The following is a description of a gene set: from publication Fridman AL, Tainsky MA (PMID 18711403) Genes down-regulated in senescent cells. studied in species Homo sapiens Bypassing cellular senescence and becoming immortal is a prerequisite step in the tumorigenic transformation of a cell. It has long been known that loss of a key tumor suppressor gene, such as p53, is necessary, but not sufficient, for spontaneous cellular immortalization. Therefore, there must be additional mutations and/or epigenetic alterations required for immortalization to occur. Early work on these processes included somatic cell genetic studies to estimate the number of senescence genes, and microcell-mediated transfer of chromosomes into immortalized cells to identify putative senescence-inducing genetic loci. These principal studies laid the foundation for the field of senescence/immortalization, but were labor intensive and the results were somewhat limited. The advent of gene expression profiling and bioinformatics analysis greatly facilitated the identification of genes and pathways that regulate cellular senescence/immortalization. In this review, we present the findings of several gene expression profiling studies and supporting functional data, where available. We identified universal genes regulating senescence/immortalization and found that the key regulator genes represented six pathways: the cell cycle pRB/p53, cytoskeletal, interferon-related, insulin growth factor-related, MAP kinase and oxidative stress pathway. The identification of the genes and pathways regulating senescence/immortalization could provide novel molecular targets for the treatment and/or prevention of cancer. Human Gene Set: FRIDMAN_SENESCENCE_DN, and this is the list of marker genes: CDC25B, LAMA1 (laminin subunit alpha 1), MARCKS, BMI1, COL3A1, CCN4 (cellular communication network factor 4), ALDH1A1, CKS1BP7, LDB2, ID1, CCNB1, EGR1, E2F4